Given this list of marker genes IGKV3-20, IGHA1, PIGR, JCHAIN, IGHA2, here is a description of the gene set: A protein complex composed of two identical immunoglobulin heavy chains of an IgA isotype and two identical immunoglobulin light chains, held together by disulfide bonds, sometimes complexed with J chain or J chain and secretory component, and present in the extracellular space, in mucosal areas or other tissues, or circulating in the blood or lymph. Human Gene Set: GOCC_IGA_IMMUNOGLOBULIN_COMPLEX_CIRCULATING studied in species Homo sapiens